The following is a description of a gene set: Mouse Gene Set: GOBP_POSITIVE_REGULATION_OF_ISOTYPE_SWITCHING species: Mus musculus Any process that activates or increases the frequency, rate or extent of isotype switching., and this is the list of marker genes: Paxip1, Il2, Cd28, Shld1, Tnfsf13, Clcf1, Shld3, Ifng, Tgfb1, Tfrc, Kmt5b, Rif1, Exosc3, Stat6, Shld2, Mad2l2, Ptprc, Pms2, Il4, Atad5, Msh2, Tnfsf4, Cd40, Hmces, Mlh1, Nsd2, Exosc6, Pagr1a, Kmt5c, Tbx21, Trp53bp1